The following is a description of a gene set: species: Mus musculus from publication Yevshin I, Sharipov R, Kolmykov S, Kondrakhin Y, Kolpakov F (PMID 30445619) Mouse Gene Set: GM14412_TARGET_GENES, and this is the list of marker genes: Rnf44, Ubn1, Msl1, Aen, Eif3e, Sltm, Abhd18, Zbtb25, Gnptg, Xpo1, Ptk2b, Ankrd24, Ckap2, Chic2, Dda1, Alcam, Rbfox3, Tmem178b, Cars1, Unc119b, Emc4, Rpl10-ps2, Fus (NCBI Gene Id 338527), Gpn3, Got1, Angptl1, Tjp2, AI837181, Trub1, 4930539J05Rik, Srsf1, Osgin2, 2610206C17Rik, 4930449I04Rik, Srp68, Kif4, Cux2, Pphln1, Art1, Ndufaf1, Kat2b, Zfp503, Ptbp1, Carnmt1, Hsp90ab1 (heat shock protein 90 alpha (cytosolic), class B member 1), Smim14, Eps15, Pnma2, Cep126, Abhd17b, Zfp292, Art5, Tpt1, Fbxw11 (F-box and WD-40 domain protein 11), Fam216a (NCBI Gene Id 68948), Neat1, Gm37201 (predicted gene, 37201), Pik3r1, Pparg, Elf1, Fzd9, Gm15579, Zfp703, Pitpnm2, Glod4, H2af-ps2, Dhps, Boll, Spns1, C230096K16Rik, Dcaf17, Adprs, Gm8399, Fgf16 (fibroblast growth factor 16), Socs3, 2810403D21Rik, Lrrc24, Lhx2, Atosb (atos homolog B), Gabarapl2, Retreg3, Gm17733, Zzz3, Fam20a, C1ql2, Mgrn1, Gm24381 (predicted gene, 24381), Cbfb, Drap1, Pwwp3b, Zbtb1, Qrich1, Gpx8, Prrg2 (proline-rich Gla (G-carboxyglutamic acid) polypeptide 2), Mettl8, Rbm6, Eif5b, Smox, Eno4, Pitx3, Lrtm2, Brwd3, Antkmt, Dip2b, Foxd2os, Chi3l1, Hmgb1, 1700025H01Rik, Cul5, Nr4a2, Rnf10, Gng3, Dmac2l, Jak2, Pdzd11, Lyset, Rasgrp1, Kcnd3, Nrsn1, Sncb, 2810002D19Rik, Tpst2, Impdh2, C1ql4, Cox6b2, Gucy1a2, Ppp1r12c, Gm6872, 3110031N09Rik, Pax5, Mir320 (NCBI Gene Id 723838), Tex30, Klf2, Vcl, Lyrm4, Uba52, Kcnb2, Elfn2, Car3, Hoxa13, Gm27343, Rbbp7, Mlxip (NCBI Gene Id 208104), Polr1a, Atrn (attractin), 6430590A07Rik, 2310014F06Rik (NCBI Gene Id 69625), Akt2, Dusp15 (NCBI Gene Id 99102), Rora, Ptcd3, Dlgap4, Limk2, Selenop, Ttll11, Srpk2, Asic4, Gm12980, Cdca7, Gm9506, Wnk4, Ctbp2, Ppara, 1110028F18Rik, Ammecr1, Rheb, Gm19721 (predicted gene, 19721), Gm12500, Gm5417, Tecpr2, Camk2b, Wrn, Rock2, Dnmt3a, Tmem183a, Cadm4, Fgf5, Taf3, Polr3d, Phyh, Slc16a10, Rph3a, Bloc1s4 (NCBI Gene Id 70328), Arhgap26, Mapk14, Gm25268, Bloc1s2, Cplane1, Acsl4, Angptl4, Mctp2, Tmeff2, Phaf1, Ttc7, Vegfc, Memo1, Cbln1, Tle2, Robo4, Acad10, Gm9958, Zfp637, Zbtb8a, Tfap2c, Nrip1, Dnajb6, Jph1, Gm10062, Clvs2, Dhrs3, Misp3, Rbpj, Acot7, Eef2k (NCBI Gene Id 97404), Niban2, Slmap, Csnk1g1, Mzt1, Mast1, Il1rapl2, Bscl2, Esrp2, Cops5, Zfp395, Gm27003, Adgrl3, 1700024G13Rik, Srebf1, Xpo4, Gm26871, Slc18a3, Pabpc4, Grik4, Pabpc1, Ccdc8, Dnaaf9, Rbm5, Leng8, Gli2, Col18a1, Phkb, Fars2, Ube4b, Tcf4, Cpeb3, Plcl2, Ptprn2, Nfkb1, Zfp398, Gm13392, Gfra2, Frmd8os, Mfsd12, Dnah17, Nipbl, Mycl, Eda, Riok3, Bmt2, Gm11957, Mir1199, Zic2, Marchf6, Chsy1, Ophn1, Gm26885, Gm16630, Peg12, Raph1, Matr3, Rad51c, Mgst3, Cers6, Sos2, C630004M23Rik, C920021L13Rik, Epha7, Tmed2, Herc1, Slit2, Gm15939, Vezf1, Setd7, Fads1, Zc3h12b, Smchd1, Paupar, Zdhhc21, Osgin1, Gm22122, AU015836, Ak1, Dpy19l1, D030056L22Rik, Zfp64, Rab14, Plod3 (NCBI Gene Id 26433), A730035I17Rik, Platr22, Tmed1, Cryzl1, Scin, Pbx3, Gm15270, Brd10, Cinp, 1810021B22Rik, Bola2, Phka2, Ctnnbip1, Pank2, Elmo2, Slc12a2, Immp1l, Nfkbil1 (nuclear factor of kappa light polypeptide gene enhancer in B cells inhibitor like 1), Mfsd4a, Map2, Gm2058, Taf6l, Tor1aip2, Gm715, Trim45, Tbc1d7, Ttf1, Vwa5b2, Nalf2, Ifrd1, Nfat5, Hspa4l, Adcy9, Lcorl, Stoml3, Gm24851, Map1a, Snrpe, Cpsf6, Gm37125, Tra2a, Mir8109, Wnt3a (NCBI Gene Id 22416), Slc25a44, Ino80dos, Ubap2, Tmem52, Reep2, Sec16a, Angel1, Qsox1, Zdhhc3, Otud4, Plekhb1, Erf, Echdc2, Ino80d, Leprotl1, Taok2, Rnf216, Celf2, Inpp5f, 2610035F20Rik, Reps1, Ncoa4, Tmem215, Btbd3, Foxo3, Wnt7b, Ntng1, Rad50, Ubl3, Tgfbr3, Tmem86a, Tex14, Nhsl2, Nsmaf, Mycbp2, Atf7ip (NCBI Gene Id 76012), Dcakd, Septin8, Dchs2, Tm2d2, Trip4, Gm20033, Sinhcaf, Lmtk2, Elp4, Mllt11 (myeloid/lymphoid or mixed-lineage leukemia; translocated to, 11), Ptpn11, Pde1b, Ppard, Ddx27, Exosc10, Senp8, Gm5843, Thoc1, Mrps21, Bmal1, Ebf2, Enah, Mir3078, Ndrg2, Agap1, 4833439L19Rik, Psmb6-ps, Lhfpl6 (LHFPL tetraspan subfamily member 6), Carmil3, Cep76, Nosip, Klf3 (NCBI Gene Id 319260), Creb1, Vps54, Ccn3, Bcl2l1, Carhsp1, Srgap1, Morrbid, Rgs16, Galnt1, Smap1, G3bp2, Rchy1, Stard5, Gata1, Nln (neurolysin (metallopeptidase M3 family)), Tiparp, Nkrf, Dtwd2, 1500009L16Rik, Hp1bp3, Rabl6, Chn2, Kcnd3os, Ube2d3, Ppp4r4, Gpr19, Satb2, Scarna2, Stk38, Jag1, Adipor2, Rfx3, Hoxa11, Eno2, Ptprs, Rpl15-ps6, Tc2n, Tmem150a, Src, Krba1, Ankrd17, Gramd1b, Man1a2, A730017L22Rik, Glo1-ps, Zcrb1, Vamp1, Tor1aip1, Lonrf2, Txndc9, Trim33 (NCBI Gene Id 99609), Cypt3, Etl4, Sgtb, Snx6, Gm9916, Zc3hc1, Pcdh17, Triobp (NCBI Gene Id 545118), Gm2990, Dnajb1, Mrpl14, Net1, Atoh8, Smarcc1, Gm15651, 1810019D21Rik, Cfl2 (cofilin 2, muscle), Ttll6, Ccdc167, Cdk4, Rap1a, Amer1, Fam120a, Gm13523, Gcc2, Mak16, Dnajc15, Atoh1, Atp6v1g2, Arrdc3, Spg11, Fam76a, Pcyox1, 2810408A11Rik, Nrg3, Psmg2, Habp4, Zfp422, Pnpla8, Plekha8, Zfas1, Mlh1, Gm14066, Rell1, Cblc, Lap3, Capn7, Hoxd3os1, Slx1b, 1700034P13Rik, Shroom3, Rpgrip1l, Rfx2, Uvrag, Mfsd10, Snx14, Smad5, Guf1, Ntn1, Ntmt1 (NCBI Gene Id 99157), Hoxa3, A230028O05Rik, Foxd2, Mapk7, Wdr26, Hdlbp, Eefsec, Mir137, Zfp382, Gm14210, Scml4, Mdk, Gm15782, Tpr, Rab40c, Ccar2, Slc2a3, Gm42918, Dgki, Tpk1, Prdm13, Slc1a2, Caprin2, Hoxd3, Flrt2, Clic3, Gm10190, Surf6, Scpep1, Plcxd2, Gm17396, Thap6, Slc4a4, Kansl1, Lat2, Npl, Lmo2, Mtmr7, Pkm, Hdac6, 5730480H06Rik, Gprc5a, Ankrd9, Insyn2a, Ccdc85b, Rnf139, Nherf2, Smpd5, Slc35e1, Rnf6, Syk, Rpl37a, Zscan21, Bnc2, Ube2d2a, Rtn4, Sdf2, Eif1ad8, Recql5, Dvl1, Gm11893, Gm25878, Gm12830, Tmem267, AU022754, Foxb2, Rbks (ribokinase), Brap, Fam135b, Itfg1, Rab13, Zmiz1, Olig3, Ism1, Mis18bp1, Tram1, Epb41l5, Arid1a, Fgfr3, Zfp609, Uba2, Safb, Slc9a8, St3gal2, Vwf, Tsc22d1, Adcy2, Mme, Ubqln4, Gga2, Tll1, Cyp4f17, Gtf2a1, Mgat5b, Pgd, 4930404H24Rik, Etohd2, Cdkn2c, 1700095J07Rik, Ampd2, Alg6, Ctu2, Ppfibp2, Neurl4, Trp53rka, Tubg1, Cdh11, Itsn1, Abcg4, Il17rd, Ap1s2, Zcchc14, Spry4, Chga, Mtmr4, Stub1, Gtf2ird1, Znfx1, Midn, Nprl3, Gm16283, Tatdn2 (NCBI Gene Id 381801), Grk2 (NCBI Gene Id 11557), Atp2a2, Trp53cor1, Rnf166, Tex10, Gjc1, Nedd9, Kansl3 (NCBI Gene Id 98416), Wdr12, Usp1, Wiz, Mcrip1 (MAPK regulated corepressor interacting protein 1), Dnajb2, Crnde, 1700028D13Rik, Ppfia2, Trim28, Cldnd1, Nrg1 (neuregulin 1), 1110059E24Rik, Scmh1, Ptp4a1, Isoc2a, Kctd15, 4833418N02Rik, Fignl1, Ywhag, Kcnip4, Mir8104, Trabd, Dyrk1a, Klhl23, Tmem170b, Gpr63, Mid2, Odr4, E2f3, Rsph3b, Dlgap1, Phip, Shb, Zswim5, Rcan2, Inka2, Cpeb2, Cox17, Ube2i, Mapt, Dlx5, Dalrd3, Ggta1, Rap1gds1, Kcnt2, Hspe1-ps5 (heat shock protein 1 (chaperonin 10), pseudogene 5), Adarb1, Trim23, C330002G04Rik, Cmtr1, Gm16638, Ldlrad4, Polrmt, Nhsl3, Nmd3, Med18, Fam168b, Akap13, Gm16096, Sppl2c, Rbms3, Slc39a14, Olfm3, Snx10, Dlgap5, Rimkla, Gulp1, Pou2f2, Dync1i2, Strip1, Fgfr2, Bcas1, Gm5129, St7, Junos, Hoxa11os (homeobox A11, opposite strand), Adamts6, Mxd3, Exosc7, Vars2, Sergef, Vdac1, Gm16938, Pknox1, Smg7, Pan3, Cxxc4, Gm8666, Gm17435, Gnpat, Thoc7, Map4, AA474408, Hs3st3a1, Mink1, Purg, Arg2, Rxrg, Rhob, Sirt6, Egr3, Zfp36, Dhx30, Spin2c, Safb2, Prkar2b, Csnk2a2, Afmid, Ube2k